Given this list of marker genes TNRC6C, PSMC5, CDC42EP2, PSMD6, PSMB1, AGO1, TNRC6B, CDC42EP3, PSMC1, PRKACA, UBC, PRKACG, UBA52, PAK2, CDC42, CDC14B, PSMC4, MIR34B, AGO4, TNRC6A (NCBI Gene Id 92763), CDC14A, ETV4 (ETS variant transcription factor 4), PSMD1, MYC, RAC1, UBB, MMP2, PSMB2 (proteasome 20S subunit beta 2), PSMB7, DNAJB1, CDC42EP5, MMP10, MAPK6 (NCBI Gene Id 5597), HSPB1, PSMA7, AGO3, AGO2, PSMC2, CCND3, PSMA5, MOV10, RAG2, XPO1, PSMB3, FOXO1, PSMD2, PSMD13, PSMB5, PAK1, PRKACB, PSMA3, PSMB6, SEM1, MAPK4, NCOA3, PSMD12, PSMA6, PSMC3, KALRN, PSMA1, MAPKAPK5, PSMD11, MIR34C, PSMD8, PSMD3, SEPTIN7 (septin 7), FOXO3, PAK3, PSMD7, ADRM1, PSMA4, IGF2BP1, RPS27A, JUN, PSMC6, PSMD14, CDK1, RAG1, PSMB4, PSMA2, here is a description of the gene set: species: Homo sapiens MAPK6/MAPK4 signaling Human Gene Set: REACTOME_MAPK6_MAPK4_SIGNALING